Given this list of marker genes ERBB3, KTN1, PHLDB3, FAM98A, CBFA2T2, GPR162, GALNT17, CLDN9, COL18A1, LNX2, EGLN1, FGF9, RAC2, SYT2, FRMPD1, KCNE5, TUBA4A, KDM4C, TICAM1, SOX12, RAB26, PTK7, LYPD1, POLR1D, CRLF1, CALN1, PLAGL2, FIG4, OMG, EXOC6, UNC13B, FES, CHD6, SLC5A3, CCDC191, CLEC14A (NCBI Gene Id 161198), GPR37, ANKRD13B, TAFAZZIN, CALY, SPINDOC, ITSN1, HES6, EPB41L4B, H2AZ1, RXRG, HBEGF, ITGA3, PSD, MPPED2 (NCBI Gene Id 744), ARRDC3, MYL6B, CACNA2D2, SCN5A, SHCBP1L, COQ10A, POLR3GL, EXOSC3, FUT8, CEP41, WFIKKN2, CHRNG, MINK1, HRH3, HOXA6, USP32P2, PLXNC1 (plexin C1), DGKD, GDPD2, GAL3ST3, FNDC5 (NCBI Gene Id 252995), PCDH1, POFUT1, CCNJL (NCBI Gene Id 79616), SHANK2, SEMA3F, HMGN2, CACNB2, EML1, SGMS1, LYSMD2, HOXB7, C1QC, TRIM37, TUBA4B, LUC7L, SOST, QTRT2, GPR173, GCNT3, JADE1, SORCS2, MEGF8, CHCHD3, PADI4, ARHGAP36, ELAVL4, ACAP1, SKA2, NHLH1, UBR3 (ubiquitin protein ligase E3 component n-recognin 3), NDUFA4L2, MYCLP1, GNAS, CYP26A1, TMEM150A, HYCC1, RANGAP1, KLHL18, APOBEC4, ARID5A, MPC2, MOSPD1, EPHB6, CA10, GRID2, HTR2C, DRP2, CELF1, ETV1, MFAP2 (microfibril associated protein 2), SERBP1, LAMC2, WNT6, NDNF, TCEAL7, CORO2A, SPOP, DDAH2, ARHGEF2, TSEN54, SEC31B, WT1, ATOH7, PRR35, CCDC85B, ST3GAL5, AGAP3, ITGA6, KCNN2, ZRANB1, GCK, TNNT2, KCNN3, CAMK2A, HID1, MIR17HG, ZMYM4, WBP2, MGAT1, ARL5B (NCBI Gene Id 221079), USP54, GABRQ, LRRC8C, USP3, SCG2, GSE1, KCNH5 (potassium voltage-gated channel subfamily H member 5), WDR81, ELMO1, ALCAM, RTP1 (receptor transporter protein 1), TMEM69, MUSK, RIMS2, SYT4, CFL1, HOXA10, PAX9, CSMD3, AP5B1, EIF4ENIF1, DCAF1, PUM3, ARHGAP44, HYAL2, NDUFB8, TNFSF13 (TNF superfamily member 13), LUC7L3, WT1-AS (NCBI Gene Id 53590), CPNE1 (copine 1), CAV3, ANKRD2, IGF1, C6orf15, CNNM2, CCNL2, CELA3A, KIF9, PRKCQ, GNG8, ELAPOR1, UBXN4, GRIK5, AP1S2, VKORC1L1 (NCBI Gene Id 154807), BCL2L1, CALB1, RARA, GNB3, PRR11, KCNK16, NSG2, KAZALD1, CELA3B, RORA, FAM53C, NAA15, EGR1, LINC01567, AK9, LINC00683 (long intergenic non-protein coding RNA 683), STC2, CBX8, HPSE2, CASKIN2, SHISA7, MT3, MIR22HG, KCNB1, RBM3, PPARGC1A, PCF11, PIM2, AGO1, ARL4A, ESRP2, TXNDC12, SRPK1, NAT9, PGF, PRICKLE1, COL11A2, PRELP, EFNA1, SLC6A7, NTRK2, UBXN10, TOR1AIP1, PTK2B, FGF11 (NCBI Gene Id 2256), TMEM17, ELF4, MLLT6, TSPAN33, SPI1, CA7, INVS, DST, CRYZL1, STIM1, WWC2-AS2, FRMD4A, TFAP4, AAK1, PAK2 (p21 (RAC1) activated kinase 2), TNFRSF21, DARS1, ABTB3, BACH1, DSCAM, LARP1B, KLF10, CKM, GABRA3, UBE2D3, PSIP1, ABLIM3, NCDN, here is a description of the gene set: Human Gene Set: MYOD_01 Genes having at least one occurrence of the motif SRACAGGTGKYG in the regions spanning 4 kb centered on their transcription starting sites. This matches the MYOD1 transcription factor binding site V$MYOD_01 (v7.4 TRANSFAC). studied in species Homo sapiens